The following is a description of a gene set: Mouse Gene Set: REACTOME_FORMATION_OF_WDR5_CONTAINING_HISTONE_MODIFYING_COMPLEXES Formation of WDR5-containing histone-modifying complexes studied in species Mus musculus, and this is the list of marker genes: Setd1a, Setd1b, Wdr5, Tada2a, Kat8, Pagr1a, Kansl1, Kat2b, Psip1, Tada3, Kdm6a, Men1, Sgf29, Ogt, Yeats2, Bod1l, Dr1, Kmt2a, Phf20l1, Zzz3, Mbip, Akap8l, Ash2l, Kat14 (lysine acetyltransferase 14), Cxxc1, Tasp1 (NCBI Gene Id 99437), Kansl3, Paxip1, Kmt2d, Kansl2, Mcrs1, Rbbp5, Phf20, Hcfc2, Wdr82, Kmt2b, Kat2a, Hcfc1